Given this list of marker genes SELENOI, PISD, CHKB, ETNK2, CEPT1, ALOX15, ETNK1, CHKA, PCYT2, here is a description of the gene set: studied in species Homo sapiens Human Gene Set: GOBP_PHOSPHATIDYLETHANOLAMINE_BIOSYNTHETIC_PROCESS The chemical reactions and pathways resulting in the formation of phosphatidylethanolamine, any of a class of glycerophospholipids in which a phosphatidyl group is esterified to the hydroxyl group of ethanolamine.